Given this list of marker genes TAF6, GJB2, TRAF3IP2, ERCC4, ARPC1B (NCBI Gene Id 10095), TP63, GJB6, MBTPS2, TERC, SLC39A4, EGFR, WAS, NPM1, DKC1, ERCC2, DDB2 (NCBI Gene Id 1643), TERT (NCBI Gene Id 7015), CTC1, ERCC5, SMC3 (NCBI Gene Id 9126), PLCD1, ATP2A2, TBX4, NHP2, MSMO1, GATA1, RAD21, BRD4, REV3L, ADAM17, UROD, TYMS, UROS, TINF2 (TERF1 interacting nuclear factor 2), CST6, PIGN, APOE, USB1, WRAP53, WIPF1, ERCC3, EXTL3, PLXND1, NIPBL, XPA, RTEL1, SMC1A, PARN, ST14 (NCBI Gene Id 6768), HDAC8, SREBF1, NOP10, XPC, here is a description of the gene set: Inflammation of the eyelids. Blepharitis Human Gene Set: HP_BLEPHARITIS species: Homo sapiens